The following is a description of a gene set: Mouse Gene Set: GOMF_SOLUTE_INORGANIC_ANION_ANTIPORTER_ACTIVITY Enables the transfer of a solute or solutes from one side of a membrane to the other according to the reaction: inorganic anion(out) + solute(in) = inorganic anion (in) + solute(out). studied in species Mus musculus, and this is the list of marker genes: Slc26a7, Slc26a11, Slc4a3, Slc4a1, Slc4a10, Slc26a3, Slc25a25, Slc4a2, Slc4a11, Slc37a1, Slc22a6, Slc26a8, Slc26a4, Slc25a24, Slc37a2, Slc4a4, Clcn3, Slc22a8, Slc25a14, Slc26a6, Clcn7, Slc4a5, Slc26a2, Slc4a9, Slc25a30, Slc26a1, Slc4a7, Slc4a8, Slc37a4, Slc26a9, Slc25a23, Slc26a5